The following is a description of a gene set: part of: Gamma carboxylation, hypusinylation, hydroxylation, and arylsulfatase activation Reactome Pathway: Gamma-carboxylation, transport, and amino-terminal cleavage of proteins This event has been computationally inferred from an event that has been demonstrated in another species.<p>The inference is based on the homology mapping from PANTHER. Briefly, reactions for which all involved PhysicalEntities (in input, output and catalyst) have a mapped orthologue/paralogue (for complexes at least 75% of components must have a mapping) are inferred to the other species. species: Mus musculus electronically inferred by orthology from the curated human pathway, and this is the list of marker genes: Bglap2, Gas6, F10, Ggcx, Proz, F9, Proc, Pros1, F2, F7